Given this list of marker genes SLC1A1, NPPA, GNA11, RUNX1, FZD7, HK2, GPR15, MIR133A1, NRP1, PDGFRB, GTF2I, CRELD1, FLRT3, GPNMB, NRCAM, APOLD1, NPR3, RRAS (NCBI Gene Id 6237), DRC1, ALPK3, ALPK2, IL12A, NFATC1, GRN, MEF2B (NCBI Gene Id 100271849), REST, JUN, RHOJ, GATA5, FLRT2, MIR200C, BAK1, MDM2, CD47, HSPA12B, FGF18, MIRLET7G, NFATC4, EPGN, ADAM15, DNMT1, SAT1, NTRK2, RAMP1, SCUBE1, GPC3, OBSL1, ITGB1, TEAD2, ITGB1BP1, EFNA3, MIR424, ZFP36L1, RGCC, S1PR1, IFT122, SMAD1, HMGA2, RECK, RARB, FKRP, COL1A2, FOXF1, TMEM215, HEY2, FASLG, MIR206 (microRNA 206), HES1, LMO4, MIR16-1, TBXT, EPHA2 (EPH receptor A2), ACTA2, COL8A2, TMEM204 (NCBI Gene Id 79652), KIT, BBS7, AGTR1, UBP1, CCN3, SFRP1, HTR2B, ERAP1, CCDC40, ADTRP, SLC31A1, SYNPO2L, CYP1B1, SMAD5, SIRT6 (sirtuin 6), RXRB, WNT3A, SFRP2, ZFPM2, ACKR3, NFE2L2, CCN1, ITGB2, LGALS8, PLCG1, MIR217, FN1, RIPPLY3, MIR483, TMED2, ADGRB3, MIR27A, DVL2, ANGPT1, PRDM1, RAC1, CACNA1C, MED12, VGLL4, CBY1 (chibby 1, beta catenin antagonist), FYN, AP1B1, MIR22, LRP1, TRAF3IP2, EPN2, PPARD, MESP2, FGF2, KCNJ8, HPGD, SLC2A10, PTPRJ, KCNJ11, MAML1, TGFBI, CCR2, TGM2, LRRC10, UBE4B, VCAM1, OPTC, ATP5IF1, PDLIM5, NDUFV2, ADGRG1, LEFTY1, PROK2, FBXW8, MED1, VAV2, PANK2, PTCH1 (patched 1), ANXA3, AQP1, CC2D2A (coiled-coil and C2 domain containing 2A), PRKDC, SYNJ2BP, MIR19B1, PDLIM1, TERT, MEIS1, XIRP2, CEMIP2, PTK7, BMPR1A, IL10, MIR195, STK4, MKS1, PTEN (NCBI Gene Id 8037), ISM1, CCN2, CDKL1, TP53, ADAM8, EPHB1 (NCBI Gene Id 2047), MIR153-1, TNFRSF1B, PDPN, VASH1, IL6R, MB, GLI2, MIR101-1, POFUT1, PLXNA4, CTNNB1, S100A7, CXCR3, SMOC2, ADAM10, ROM1, PIK3CD (NCBI Gene Id 5293), BRCA1, STK3, PI16, CIMAP3 (ciliary microtubule associated protein 3), PPP1R16B, PLXND1, PDPK1, ADPRHL1, CD36, HIF1AN, SAV1, CALCA, SLIT3, RSPO3, PAX6, GAA, VPS4B, EMILIN2, IL1A, RARA, CHRNA7 (cholinergic receptor nicotinic alpha 7 subunit), RYR1, DSG2, PTK2, DLC1, TNF, CAMP, NDNF, VASH2, SRF, SLITRK5, TPM1, SKI, IFT74, RGS2, CHD7, TGFBR3, POU6F1, RHOB, LEPR, GHSR, ANGPTL7, ZIC3, PKD1, GALNT11, SMG9, CCL11, MIR939, PKP2, EGR2, MIR200B, ERBB3, MIR342, HIPK1, DNAH5, CRIPTO, KRIT1, SEMA4A, BBS5, PTGS2, CCL2, VEGFA, ILK, OR10J5, THSD7A, CACNA1G, MIR17HG, C10orf71, SERPINE1, EP300, RYR2, MIR23A, WARS1, GNA13, COL1A1, FOXP1, NPR1, FOXO4, NOS3, MIRLET7B, FBN1, MSX2, RELA, LCN10, E2F8, GADD45A, RIN2, ACVR2B, CITED2, CFC1 (cryptic, EGF-CFC family member 1), WNT7B, MIR30C1, TENM4, LDLR, IL6 (interleukin 6), ECM1, ETV2, GJB6, MIR99B, EPAS1, ELN, ATP2B4, GJA1, DAND5, IFT52, MIR210, E2F7 (E2F transcription factor 7), TBX4, TNNT2, SMYD4, NFATC2, ACACB, LEP, NEDD4, AKAP6 (A-kinase anchoring protein 6), MIR30B, SH3PXD2B, MYLK3, PCSK5, FOXN1, MIR143, PRKCB, TIE1, RNH1, DKK1, RAPGEF3, MIR487B, ITGB3, NSDHL, MIR185, EOMES, SARS1, HAND2 (NCBI Gene Id 9464), EPN1, TBX20 (T-box transcription factor 20), MEF2D, DNAAF3, PGF (placental growth factor), MEGF8, MAPK11, PLPP3, APLN, PKD2, SORBS2, RBM15, ROCK1, ANGPTL4, GHRL, FZD1, AAMP, KRT1, MKKS, MIR204, UNC5B, FGF19, MIR15A, TYMP, JUNB, BASP1 (NCBI Gene Id 10409), MMP2, APOE, TEK, PDE2A, SNAI2, CREB3L1, CNTRL, MIR25, NRARP, COL6A1, ARID2, TAL1, ADAMTS6, ZFPM1, MIA3, CXCL12, MIR15B, MAPK3, DNAAF4, NAA15, INHBA, TGFBR1 (transforming growth factor beta receptor 1), MYL2, ANXA2, CYBB, ADAMTS19, PPP3R1, FOSL1, CCDC134, CCM2L, CDH11, IFT172, VANGL2, EPOR, ROCK2, TNNI1, MIR1224, SMO, SCN5A, DZIP1, CCM2, NR4A1, EDN2, POGLUT1, COX17, ITGA3, FOXJ1, MFGE8, IFT20, SHB, EPHA1, FAP, MIR199A1, ASCL1, EXT1, ID1, PDE3B, HDAC7, FBLN5, PRKAR1A, AGGF1, MIR451A, TMEM100, NOX5, FGF10, JMJD6 (jumonji domain containing 6, arginine demethylase and lysine hydroxylase), ASB2, SPHK2, CX3CL1, EPHB3, ABL1, MTERF4, ADGRG6, GLMN, ANGPTL6, MIR548C, TMIGD2, EFNB2, RGS4, MBD2, MIR34C, PROP1, HSPG2, C2CD3, HS6ST1, ARHGEF15, RPS6KA2, TAB1, NAGLU, SOD2, EGFR, RAMP2, MAPK1, ZNF354C, PDCD4, EGFL7, HAND1, SGCB, RBPJ, PDGFD, COL14A1, FOXC1, GAB1, QKI, AMOT, G6PD, LYL1, THBS2, SMAD6, CXCL13, NKX2-5, TCF21, TAFA5, ID2, MEF2A, STIL, SMAD4, ESM1, TRIP11, PIK3C2A, ADIPOR2, SLC8A1, DLL1 (NCBI Gene Id 28514), SOX6, DDAH1, WDPCP, DCTN5, HOXA13, JARID2, SCX, TSPAN18, NOTCH1, PSEN1, MIR138-1, CASP3, C5AR1, ROBO1, CD160, MIR106B, GREM1, KLF2, LIPA, ANGPT2, OXCT1, CTCF, NPPC, MIR27B, KDM6A, PTCD2, PRKCA, FZD2, TBX5, ABCC8, PECAM1, NCL, CTDP1, MIR590, NRP2, PDCD10, MYOCD, DSP, ATM, FGFR2, C3, MIR208A, PKM, IFT57, PAK4, CRIP1, GYS1, NUS1, FOXH1, MIR505, OTULIN, PACSIN2, CDKN1A, VSTM4, FGF20, GPER1, HTATIP2, DUSP6, MAPK14, HIF3A, PARVA, RBP4, FKBP10, FLT4, BMP7, APOD, MINAR2, FHOD3, RIC8A, ANTXR1, MIR125B1, ARHGAP24, TNFSF12, IGF1, SASH1, PIM1, MIB1, MMP19, ERBB4, SIK1, EYA1, ITGA5, HHEX, CLEC14A, KCNJ1, MIR140, MOSPD3, HEXIM1, HOPX, HIF1A, HGS, MOSMO, ATG5, MYH9, FGF9, MIR509-1, TSC1 (TSC complex subunit 1), IFT140, PLN, IL1B, MYL7, MDK, CCR3 (NCBI Gene Id 1232), MYO1E, SNAI1, MIR146A, TBX1, LMNA, HRG, ENG, NFATC3, HSPB1, DAB2IP, HLA-G, PTPN14, CXCL10, SH2D2A, GRK2, ECSCR, OVOL2, PTPRB, CPLANE2, BCAM, ATP5F1B, PRRX1, SEMA6A, MIR222, NOX1, HOXA1, MYBPC3, FLT1, NDST1, NIPBL, CNMD, WNT11, FGF1, ANG, HOXB3 (homeobox B3), TSC2, CD40, COL11A1, EGF, MIR499A, MYH7, MEOX2, WARS2, NTRK3, HOXB13, HSPB6, FZD5, MSC, DLL4, LRG1, JMJD8, VEGFD, CASP7, SOS1, EMC10, C1GALT1, THBS4, ADGRA2, PAK1, MIR361, MIR100, MIR1298, ODAD3, KDR, WDR11, SULF1, PDCL3, FOXS1, SLC9A1, PDGFRA (NCBI Gene Id 5156), MTDH, FGF6, MIR125A, NOTCH4 (NCBI Gene Id 4855), STARD13, MIR193A, TLR3, KAT2B, PTPN20, PARP2, VAV3, GREB1L, ODAD4, SOX18, LEMD2, LLGL2, DNAI1, STK11, MIR20A, ADGRF5, CLIC3, MIR223, SGCZ, NPY2R, SUFU, CTNND1, LIF, PTPRM, TNFAIP2, ITGA2B, THY1, TNFRSF12A, MIR29B1, PRKX, SOX17, PIK3R6, CD34, STAB2, MIR20B, WDR83, MIRLET7F1, CEACAM1, APLNR, ZMPSTE24, MIR18A, MIR640, MATR3, CER1, JUP, CRB2, DAW1, NPY1R, EHD4, FZD4, CLIC4, ACVRL1, IL12B, TBXA2R (thromboxane A2 receptor), SRPK2, RTN4 (NCBI Gene Id 57142), CSRP3, HYAL1, MIR19A, CHI3L1, FES, ANGPTL3, STAT1, NF1, ADM2, PLEC, MAPK7, OSR1, NRAP, SOCS3, ADAMTS9, LUZP1, KLF5, NEK8, BICC1, GATA3, INSR, HIPK2, MIR126, MIR30A, SP100, HOXA3, SP1, RORA, TMEM201, WNT16, GGNBP2, EIF2AK3, GBX2, TBX3, MAP2K2, NXN, TBX18, HOXA7, MIR34B, SCN11A, NCOA6, SGPL1, YY1, GATA6, BMPR2, EEF1AKMT4-ECE2, MYL3, NKX2-6, ZDHHC16, MTHFD1, IL18 (NCBI Gene Id 3606), AIMP1, AKT1, BTG1, FGFRL1, CPE, NRXN3, TNNC1, SYPL2, MICAL2, FREM2, MIR150, PDCD6, ARRB2, ASXL1, TFAP2B, CERT1, ROBO4, ABCC9, PTGIS, IMMP2L, PDLIM3, CX3CR1, CDKN1B, NPRL3, KRAS, TAB2, KCNK2, IGFBP7, SLC12A6, MIR26A1 (microRNA 26a-1), COL3A1, FGF8 (NCBI Gene Id 2253), CRIPTO3, CDH5, ALDH1A2, FAM3D, COL4A1, MSX1, NDUFS6, CCBE1, BMP2, SEC24B, NCKAP1 (NCK associated protein 1), SOX11, MIR149, PRICKLE1, SLIT2, B9D1 (NCBI Gene Id 27077), TNMD, KDM6B, MIR10B, ANK2, MIR199B, SENP2, MEIS3, MIRLET7A1, MIR130A, PDLIM2, CAD, EGLN1, NRXN1 (neurexin 1), COMP, YJEFN3, COL4A3 (NCBI Gene Id 200750), AKAP13, HCN4, NOTCH3, CREB1, SVEP1, PPP1R13L (protein phosphatase 1 regulatory subunit 13 like), ANXA1, MBD3, MIR329-1, GSK3A, CDX2, MMRN1, NR2E1, POU4F1, MMRN2, JAG1, MIR2355 (NCBI Gene Id 100423036), ISL1, MIR320A, NPR2, TNNI3, SPINT1, EDNRA, FRS2, FOXJ2, PDLIM4, TNFRSF1A, JPH2, FGF16, MYLK, CFC1B, LRP5, COL15A1, NAXE, PIK3CA, PRICKLE4, BCAS3, ECE1, CDX4 (NCBI Gene Id 1046), DHX36, POPDC2, FZD8, WNK1, FOXC2, STAT3, SGCG, KLF4, CIB1, SHH, MNAT1, HHIPL1, WNT4, UTY, CTH, CELA1, PRL, ID3, BORCS8, PPARG, PDGFA, GJA4, ZC3H12A, MICALL1, IRX4, FLVCR1, NKX3-1, PRKD1, GRHL2, MIR137, TBX19, FOXN4, ACTC1, BMPER, SMAD2, APOB, AP2B1 (adaptor related protein complex 2 subunit beta 1), MIR29C, RAP1A, PGK1, VEZF1, ARL13B, MIR145, CDH13, MIR492, MIR9-1 (NCBI Gene Id 407046), COL2A1 (collagen type II alpha 1 chain), NOX4, FGFBP1 (fibroblast growth factor binding protein 1), HEG1, PAXIP1, SMYD2, TSPAN12, TCF7L2, RNF207, XBP1, PIK3CB (phosphatidylinositol-4,5-bisphosphate 3-kinase catalytic subunit beta), BORCS8-MEF2B, PML, CARD10, RBM20 (NCBI Gene Id 282996), IL17F, STAB1, EPHB4, NDP, CAV1, RASA1, CALR, PITX2 (NCBI Gene Id 5308), DDIT3, ITGAX, SOX9, HECTD1, GLUL, MYO18B, MIR29A, NOTCH2, NR2F2, PSKH1, ENPEP, PLK2, APELA, SHC1, AXIN2, MIR885, STIM1, PIK3R3, MIR497, DHRS3, GLI1, EFEMP2, NRG1, YAP1 (Yes1 associated transcriptional regulator), ACTG1, NDRG4, TGFBR2, SPINK5, JCAD, ZBTB14, CAV3, CSPG4, SLC2A12, TOMM70, PIK3CG, RBM24, ANPEP, DIPK2A, RNF213, FAM114A1, DNAAF1, EDN1, MIR34A, EVA1A, GLI3, POU4F2, TREX1, EFNA1, PXDN, ADAP2, NPY5R (neuropeptide Y receptor Y5), FBXW7, FOXL1, PTPN6, FOXO1, HOXA5, TRAF3IP1, TJP1, BCOR, SPRY2, NOG, PDGFB, CLUAP1, FMNL3, HPSE, PAX8, LOXL1, KAT2A, SERPINB7, GDF2, OXT, ASB4, CDK1, SYK, MIR17, SETDB2, TBC1D32, MIR205, SGCD, ELK3, SPHK1, TMEM231, CD93 (CD93 molecule), TH, C3AR1, MCAM, VEGFB, SEMA3C, HMOX1, ATF2, CASP8, CCDC39, TNFAIP3, PCNA, TGFB1, MINAR1, SALL1, TGFA, NSD2, CXCL17, ACTN2, MYH11, ADAMTS1, MIR30E, NINJ1, WT1, RPGRIP1L, LARGE1, NOTO, MAP2K1, SCG2, PPP3CB, EPHB2, SEMA5A, MIR221 (microRNA 221), ITGAV, SMAD7, ERBB2, WASF2, COL8A1, CCNB1, TIPARP, GPR4, MIR296, SALL4, DNAH11, RB1CC1, AHR, ADGRB2, CFLAR, TGFB2, ANKS6, MEF2C, GJA5, ADGRB1, RAPGEF2, SPRED1, LDB3, MTOR, SIX1, ANP32B, JAM3, MIR21, KCNQ1, SNX17, FGF3, MIR31, DCHS1, GJC1, RHOA, GPLD1 (glycosylphosphatidylinositol specific phospholipase D1), MIR377, BMP4, JAK1, MYH6, ACVR1, GATA4, TCAP, PRKG1, PF4, HNRNPU, IRX3, BMP10, MIR873, ADAMTS5, MGRN1, AKT3, SOX4, AGO1, B4GALT1, MIR10A, MIR375, ITGB8, NEB (NCBI Gene Id 4755), F3, YWHAZ, MECP2, COL5A1, RB1, ANGPT4, IHH, MIR24-1, NTRK1, MIR410, STRA6, LAMA1, MIR1-1, PTPN11, DAG1, CCN6 (cellular communication network factor 6), CLDN5, MIXL1, SPI1, ZFAND5, MIR378A, ADAM12, CCDC103, WNT2, SIRT1, E2F2, PLCD3, FUT1 (NCBI Gene Id 2523), SLC12A2, HDAC9, BVES, ETS1, MIR1908, ATP7A, MIR503, ARHGAP22, KLK3, AGO2, HTN1, CDC42, MIR92A1, ADM, MMP21, NPHP3, MYH10, DYNC2H1, TP73, MAP2K3, APC, CCL24, PRCP, MYLK2, PPARA, CITED1, ANKRD1, SEMA3E, GPX1, MAP3K3, POU5F1, NODAL, MIR495, HDAC5, EREG, MMP14, MESP1, MIR494, HEY1, WNT7A, CALCRL, PDLIM7, CACYBP, PROK1, PTK2B, CMA1, MEIS3P1, MIR212, PCDHA10 (protocadherin alpha 10), CUL7, LBX1, PRKD2, FKBPL, TBX2, ADRA1A, ROBO2, ERRFI1, MIR132, APOH, ZNF304 (zinc finger protein 304), TGFB3, S100A1, EMILIN1, ZMIZ1, PKNOX1, THBS1, EGFL8, EMP2 (epithelial membrane protein 2), SHOX2, RASIP1, LOX, FOLR1, CXCR4, SPARC, TTN, DVL1, HAS2, SPRY1, LOXL2 (NCBI Gene Id 4017), FGF12 (NCBI Gene Id 2257), POPDC3, SMARCD3, NACA, PRMT1, MIR214, RLN2, COL18A1, CXCL8, SMAD3, FKBP1A, IFT25, GATA2, PROX1, HDAC3, HMGB1, ACADM, TNN, NPPB, HEYL, ODAD2, COMT, FGFR1, EGR3, PLG, MIR181B1, SERPINF1, CRKL, VEGFC, SMYD1, AMOTL2, LRP2, TMEM65, NGFR, FHL2, EGR1, CXADR, SRPX2 (sushi repeat containing protein X-linked 2), MYDGF, ALOX5, AMOTL1, DLX3 (NCBI Gene Id 1747), HSPB7, LEF1, BMP5, BAX, TWIST1, CDH2, DCN, MAP2K5, OLFM1, BSG, SERPINF2, WNT5A, COL4A2, MDM4, NEBL, MIR196A1, AHI1, PLXDC1, here is a description of the gene set: Human Gene Set: GOBP_CIRCULATORY_SYSTEM_DEVELOPMENT species: Homo sapiens The process whose specific outcome is the progression of the circulatory system over time, from its formation to the mature structure. The circulatory system is the organ system that passes nutrients (such as amino acids and electrolytes), gases, hormones, blood cells, etc. to and from cells in the body to help fight diseases and help stabilize body temperature and pH to maintain homeostasis.